Given this list of marker genes Col4a5, Itgae, Fgg, Itga2, F11r, Itga5 (integrin alpha 5 (fibronectin receptor alpha)), Fga, Itgb8, Icam5, Madcam1, Col6a3, Fgb, Col9a2, Itgb1, Col1a2, Col4a4 (collagen, type IV, alpha 4), Icam2, Itga8, Itgal, Itga2b, Col6a1, Itga10, Itgax, Col6a5, Col4a6, Col2a1, Tnc, Itgb3, Col9a1, Ibsp, Col5a1, Itgb7, Fn1, Col9a3, Col5a3, Itga3, Itga1, Col4a2, Col4a3, Itga9, Col4a1, Col6a2, Thbs1, Col18a1, Col13a1, Itgam, Fbn1, Itgb2 (integrin beta 2), Itga11, Itga4, Cd44, Col8a2, Icam1, Col8a1, Col3a1, Pecam1, Vwf, Bsg, Itgad, Jam3, Jam2, Cd47, Col16a1, Itgav, Col6a6, Vcam1 (NCBI Gene Id 22329), Col7a1, Comp, Col5a2, Itgb6 (integrin beta 6), Col1a1, Vtn, Icam4, Lum, Spp1, Itga6, here is a description of the gene set: Integrin cell surface interactions Mouse Gene Set: REACTOME_INTEGRIN_CELL_SURFACE_INTERACTIONS studied in species Mus musculus